Given this list of marker genes TPRN, SIRPA, JAK3, PTK2, MYO16, HSF4, AKAP11, MFHAS1, SNX3, IKBKE, PPP6R1, PPP3CB, PPME1, STRN3, CDH2, GHR, STAU1, ARPP19, FBXL2, PPP1R3B, ANAPC5, MET, AP3B1, PTPN1, GNA12, KAT2A, PPP1R3C, CLEC12B, TRAF3, PPP1CA, VCP, SLC9A1 (solute carrier family 9 member A1), PTPRT, CD33 (CD33 molecule), PABIR1, ANAPC4, EGFR, PPP1R3E, MTMR3, MAP3K5, TBK1, MYOZ2, PPP1CC, PTPA, LILRB4, PHACTR4, CADM4, SH3RF2, CD22 (CD22 molecule), PIK3R2, MAPK14, AMBRA1, GRB2, FER, FOXO1, BCL2, CTNNB1, ROS1, CDC27, KIF3A, MASTL, IGBP1, NFATC1, LILRB1, MAP2K7, JUP, SHOC2, PPP1R3F, TRAF2, RACK1, CTTNBP2NL, DLG4, SMG7, PPP6R3, ADCY8, STAT3, IRS2, ANK1, DAB2IP, PPP1R3G, MVP, SMG5, SMTNL1, RPA2, HSP90AA1, PPP1R3D, TP53, MAPK8, PPP1R15A, FCRL2, LGALS3, STYXL1, GIT1, HSP90B1, PPP1R3A, STX17, MTMR9, ANAPC7, PPP1R10, PPP1R9B, JAK1, CSF1R, SOD1, VRK3 (VRK serine/threonine kinase 3), MAPT, CDH5, FLT4, KCNN4, FCRL6, LCK, YWHAE, PPP6R2, CSK, GRIN3A, ENSA, KCNQ1, ATP2B4, CFL1, PPP2R2A, SKAP1, AKAP5, STAT1, IQGAP1, STRN4, ITGA1, BOD1, GTF2F1, EIF2AK3, ADISSP, ANKLE2, STAT6, MTMR4, LILRB2, CDKN1B, PIK3R1, PDLIM4, PXN, BAD, IGBP1C, STRN, CACNG8, SPHK1, MARK3, CEACAM1, SLC6A3, YWHAZ, PPP1R11, DYNLT4, NEK2, KIFAP3, here is a description of the gene set: Binding to a protein phosphatase. Human Gene Set: GOMF_PROTEIN_PHOSPHATASE_BINDING species: Homo sapiens